Given this list of marker genes PMEL, AP3D1, TYRP1 (NCBI Gene Id 7306), AP1B1, AP1S3, HPS6, BCL2, HPS1, SNAPIN, BLOC1S3, ZEB2, AP1S1, AP1S2, LYST, GPR143, ABCB6, RAB29 (RAB29, member RAS oncogene family), AP3M1, BLOC1S6, AP1M1, BLOC1S5, DTNBP1, RAB38, HPS5, BLOC1S4, AP3S1, KIF13A, AP1G1, BLOC1S1, HPS4, AP3B1, BLOC1S2, APOE, BACE2, PIKFYVE, AP3S2, SHROOM2, HPS3, RAB32, ASIP, here is a description of the gene set: Human Gene Set: GOBP_PIGMENT_GRANULE_ORGANIZATION species: Homo sapiens A process that is carried out at the cellular level which results in the assembly, arrangement of constituent parts, or disassembly of a pigment granule.